The following is a description of a gene set: from publication Wiemann SU, Satyanarayana A, Buer J, Kamino K, Manns MP, Rudolph KL (PMID 15608677) Telomere shortening limits the regenerative capacity of cells during aging and chronic disease but at the same time inhibits tumor progression, and it has yet to be determined which of these mechanisms is dominantly affecting organismal survival. Here we show that telomere shortening in telomerase knockout (mTERC-/-) mice in combination with chronic liver damage significantly reduced organismal survival even though telomere shortening strongly inhibited liver tumor formation. Decreased survival induced by telomere shortening correlated with an imbalance between liver cell proliferation and liver cell apoptosis. Specific changes in gene expression were associated with telomere shortening and chronic liver damage and these gene expression changes were partially reversed by adenovirus mediated telomerase gene delivery. This study gives experimental evidence that the negative impact of telomere shortening on organ homeostasis and organismal survival can surpass the beneficial effects of telomere shortening on suppression of tumor growth in the setting of chronic organ damage. Mouse Gene Set: WIEMANN_TELOMERE_SHORTENING_AND_CHRONIC_LIVER_DAMAGE_DN Genes down-regulated by telomere shortening due to the knockout of TERC in the presence of chronic liver damage. species: Mus musculus, and this is the list of marker genes: Nr1d2, Ngp, Hmgcr, Cyp2c39, H19, Ccl5 (C-C motif chemokine ligand 5), S100a9